The following is a description of a gene set: Human Gene Set: GSE3982_DC_VS_NKCELL_DN from publication Jeffrey KL, Brummer T, Rolph MS, Liu SM, Callejas NA, Grumont RJ, Gillieron C, Mackay F, Grey S, Camps M, Rommel C, Gerondakis SD, Mackay CR (PMID 16474395) In the present study we used Affymetrix oligonucleotide microarrays to produce gene transcription profiles for the major leukocyte types in humans. This comprehensive dataset enabled us to not only establish which genes were expressed in each leukocyte type, but also which genes were expressed in each subset after activation. The used of a comprehensive dataset of gene profiles from all the major human leukocyte subsets enabled a novel and powerful means for identification of genes associated with single leukocyte subsets, or different immune paradigms. studied in species Homo sapiens Genes down-regulated in comparison of dendritic cells (DC) versus NK cells., and this is the list of marker genes: NUCB2, SUN2, UBR7, HECW1, CNTNAP1, ZNF22, MEF2C, NOL6, SECTM1, TXK, PDE1C, VGLL4 (NCBI Gene Id 9686), MAGEC2 (NCBI Gene Id 51438), SEC14L5, EPPK1, SMG7, PITPNC1, SAP30L-AS1, FRMPD1, MRPL49, GVINP1, B3GALT5, TUBA4B, SPOCK2, RYR2, AKR1C4, CYP3A7, TNFSF10, IFT46, NCBP3, RHOH, PTCH1, GCNT4, PTPRD, GAST, PCID2, THBS4, TSPAN7, AKAP6, CHRNA9, TPX2, KIR3DL1, FAM117A, GLOD4, IRF7, PMP2, MYL1, ZNF506, DYM, CDC37L1, FOXJ2, EIF4EBP2, NRN1, CTDSP2, KRT5, CYP1A2, PASK, EN2, CD160, INAVA, DENND1C, IFITM2 (interferon induced transmembrane protein 2), H2AP, CD34, ITK, SELL, CTCF, HLA-A, NMNAT2, CPA3, TRRAP, RAB11FIP5, NCAM1, ESM1, DVL3, INCENP, POLR1G, DLGAP2, SEPTIN6, PDE4D, IFITM1, TBX21, GSTA1, MEFV, USP7, UBE2NL, SP140, LINC01278, STAP1, SYNE2, DIDO1, PMEL, GIMAP6, PSG7, OR7C1, ZNF8, GABPB1, SIDT1, CD72, WDR37 (WD repeat domain 37), RNF144A (NCBI Gene Id 9781), TMSB15B, MYO5C, SYNE1, NME7, PICK1, ALOXE3 (NCBI Gene Id 64048), RPS3A, FCGR3B, FAM193B, MLLT11, CENPA, HCP5, CCDC177, ABLIM1, LETM1, MARCKSL1, ANKRD17, CCDC81, SH2D3C, OSBPL2, VAMP1, ZPBP, AICDA, BCL7B, ZNF287, CHRNB4, MAP3K1, SH2D2A, DENND2D, ZNF394, AREL1 (apoptosis resistant E3 ubiquitin protein ligase 1), VNN2, PLAAT4 (NCBI Gene Id 5920), YLPM1, RPL6, CTIF, TRGV5, ACKR3, CATSPERB, KCNJ9, ATF7, HAVCR1 (hepatitis A virus cellular receptor 1), TPM3, OR12D3, SPTBN1, MYBL1, BCL2, BTN3A3, RNF44, FLT3LG, CPSF4, ARHGEF18, CHD7, RBM14, FLRT3, COLQ, MFSD13A, GCH1, NAP1L2, GFI1, MAPRE2, ZNF473 (NCBI Gene Id 92653), MLLT10, CYTH1, ZNF586, TSPYL2, KLRC3, TRIM49, GRM1, CST7, SPTBN2, PCDHB17P, SULT1E1, RPIA, HCRTR2, STK32B, MYT1L, BEGAIN, CDCA4, TGFBR1, SHFL, PCNT, RAF1, CTBP1, SLC25A16, CSK, HCG9, LPAR4, FAM110D, FTSJ1, ENSG00000290731, VN1R1, AKR1C3, KLRB1, RBCK1, MCTP2, LPAL2